The following is a description of a gene set: studied in species Homo sapiens Human Gene Set: GOBP_CELLULAR_RESPONSE_TO_EXOGENOUS_DSRNA Any process that results in a change in state or activity of a cell (in terms of movement, secretion, enzyme production, gene expression, etc.) as a result of an exogenous double-stranded RNA stimulus., and this is the list of marker genes: IRF3, TLR3, ZCCHC3, IFNB1, OAS1, MUL1, MAVS, PQBP1, DHX9, IFIT1, CAV1, IFIH1, COLEC12, RALB, STING1, OAS3, RIGI (NCBI Gene Id 23586), CGAS, FLOT1